The following is a description of a gene set: NF1 copy number variation syndrome studied in species Homo sapiens Human Gene Set: WP_NF1_COPY_NUMBER_VARIATION_SYNDROME, and this is the list of marker genes: OMG, USP1, MIR193A, MIR4733, EGFR, EXOC6, RAD51, RFC3, SYN1, ROCK2, EED, POLRMT, MAP3K2, H4C13, EXOC2, NGFR, EXOC4, HOXA1, RFC5, H4C9, MAP3K1, EXOC3, RIGI, ENSG00000291063, H3C6, H3C8, CRY1, RBBP7, RAB11A, UTP6, LIMK1, EZH1, H3C4, DNMT1, RAB11FIP4, PCNA, ADAP2, EXOC8, BCL2, EVI2A, ATR, NGF, EXOC1 (NCBI Gene Id 55763), COPRS, MAPK1, EXOC7, H3C7, RHOA, H4C1, SOS1, HOXA9, ATAD5, RTN4R, EXOC5, H4C14, H3C10, RNF135, E2F6, CCNE1, H4C5, EVL, H4C16, PER1, H4C15, H3C1 (NCBI Gene Id 8350), RAD9A, WDR48, CRLF3, SUPT5H, H4C11, H4C8, METAP2, CFL1, H3C12, INPP5A, CCNA2, EIF3A (NCBI Gene Id 8661), SDC2, H4C2, EVI2B, MIR4725, IFNB1, H3C14, H4C4, H4C3, H3C3, H4C12, H4C6, H3C11, MAVS, MCL1, SUZ12, EGF, PRMT5, ARF6, CCNE2, ADAMTSL4-AS1, RAF1, MAPK3, JARID2, TUBB, NF1, TEFM, H3C13, MYT1, H3C2, RFC2, H3C15, RFC4